The following is a description of a gene set: We mapped quantitative trait loci that accounted for the variation in hematopoietic stem cell (HSC) numbers between young adult C57BL/6 (B6) and DBA/2 (D2) mice. In reciprocal chromosome 3 congenic mice, introgressed D2 alleles increased HSC numbers owing to enhanced proliferation and self-renewal and reduced apoptosis, whereas B6 alleles had the opposite effects. Using oligonucleotide arrays, real-time PCR and protein blots, we identified latexin (Lxn), a gene whose differential transcription and expression was associated with the allelic differences. Expression was inversely correlated with the number of HSCs; therefore, ectopic expression of Lxn using a retroviral vector decreased stem cell population size. We identified clusters of SNPs upstream of the Lxn transcriptional start site, at least two of which are associated with potential binding sites for transcription factors regulating stem cells. Thus, promoter polymorphisms between the B6 and D2 alleles may affect Lxn gene expression and consequently influence the population size of hematopoietic stem cells. Human Gene Set: LIANG_HEMATOPOIESIS_STEM_CELL_NUMBER_QTL studied in species Mus musculus Genes changed in LSK cells (bone marrow) as a function of a QTL for the size of hematopoietic stem cell (HSC) population: comparison of reciprocal congenic strains D.B. Chr3 (DB), B.D. Chr3 (BD) and the parental strains B6 and D2. from publication Liang Y, Jansen M, Aronow B, Geiger H, Van Zant G (PMID 17220891), and this is the list of marker genes: GFI1B, FCER1A, CEP89, S100A11, SMIM7, TUBA1A, RASGRP2, FADS1, GTF3A, NPTX1, TLCD4, S100A6, PTTG1, APLP2, MAPK8, LXN